The following is a description of a gene set: Human Gene Set: GUENTHER_GROWTH_SPHERICAL_VS_ADHERENT_DN studied in species Homo sapiens Tumor cells with stem cell-like properties can be cultured from human glioblastomas by using conditions that select for the expansion of neural stem cells. We generated cell lines from glioblastoma specimens with the goal to obtain model systems for glioma stem cell biology. Unsupervised analysis of the expression profiles of nine cell lines established under neural stem cell conditions yielded two distinct clusters. Four cell lines were characterized by the expression of neurodevelopmental genes. They showed a multipotent differentiation profile along neuronal, astroglial and oligodendroglial lineages, grew spherically in vitro, expressed CD133 and formed highly invasive tumors in vivo. The other five cell lines shared expression signatures enriched for extracellular matrix-related genes, had a more restricted differentiation capacity, contained no or fewer CD133+ cells, grew semiadherent or adherent in vitro and displayed reduced tumorigenicity and invasion in vivo. Our findings show that stable, multipotent glioblastoma cell lines with a full stem-like phenotype express neurodevelopmental genes as a distinctive feature, which may offer therapeutic targeting opportunities. The generation of another distinct cluster of cell lines showing similarly homogeneous profiling but restricted stem cell properties suggests that different phenotypes exist, each of which may lead to the typical appearance of glioblastoma. from publication Günther HS, Schmidt NO, Phillips HS, Kemming D, Kharbanda S, Soriano R, Modrusan Z, Meissner H, Westphal M, Lamszus K (PMID 18037961) Genes down-regulated in glioblastoma cell lines displaying spherical growth (cluster-1) compared to those displaying semiadherent or adherent growth phenotype (cluster-2)., and this is the list of marker genes: MVP, PLAUR, CASP1, CD46, ITGB1, COL18A1, FN1, MEIS3P1, TGFB2 (NCBI Gene Id 7042), CTSD, VCL, MET (MET proto-oncogene, receptor tyrosine kinase), CD44, TGFBR2, GAA, IL13RA1, PXN, NR3C1, PRKCD, CCND3, NRP1, PRSS23, CD59, NQO1, CAV1, ANXA5